The following is a description of a gene set: The gene expression program underlying the specification of human cell types is of fundamental interest. The study authors generated human cell atlases of gene expression and chromatin accessibility in fetal tissues. For gene expression, the study authors applied three-level combinatorial indexing to >110 samples representing 15 organs, ultimately profiling ~4 million single cells. The study authors leveraged the literature and other atlases to identify and annotate hundreds of cell types and subtypes, both within and across tissues. Our analyses focused on organ-specific specializations of broadly distributed cell types (such as blood, endothelial, and epithelial), sites of fetal erythropoiesis (which notably included the adrenal gland), and integration with mouse developmental atlases (such as conserved specification of blood cells). These data represent a rich resource for the exploration of in vivo human gene expression in diverse tissues and cell types. Human Gene Set: DESCARTES_FETAL_CEREBRUM_ASTROCYTES studied in species Homo sapiens from publication Cao J, O'Day DR, Pliner HA, Kingsley PD, Deng M, Daza RM, Zager MA, Aldinger KA, Blecher-Gonen R, Zhang F, Spielmann M, Palis J, Doherty D, Steemers FJ, Glass IA, Trapnell C, Shendure J (PMID 33184181) Marker genes curated from the annotated cluster as represented in the Descartes Human Gene Expression During Development database., and this is the list of marker genes: ADAMTS12, NCKAP5-IT1, NEK5, PPP1R9A-AS1, PDLIM3, CFAP46, ZBBX, LINC01354, PI15, SPATA17, WARS2-IT1, HS3ST3A1, CFAP99, FAM216B, LINC00844, C1QL4, ZNF474, LRRC9, AGT, SIRPB3P, SRGNP1 (NCBI Gene Id 106480246), SLC4A4, RSPH4A, SLC47A2, DNAAF3, PLA2G5, ODAD1, GREB1L, EFEMP1, CDHR4 (NCBI Gene Id 389118), ENSG00000188897, LINC03109, CFAP276, DNAH12, UBXN10, TMEM190, HKDC1, AQP4, MSTN, IRX5, PIK3C2G, CARM1P1, DRC1, GMNC, BTBD17, SPATA13, COL2A1, CKAP2LP1, CFAP157, IL33, FRMPD2, TOGARAM2, DTHD1, LINC01014, CFAP210, CLXN, WDR38, HSD17B6, COL27A1, CLDN10, LRRC74B (NCBI Gene Id 400891), FEZF1-AS1, CFAP43, THBS3-AS1, TEKT4, ADGB, GJB6, COL22A1, CFAP299, LINC00880, DNAI3, LRRC46, RPE65, TSHR, DRC7, ENTPD2, HOATZ, RNY1P5, VCAM1, ENSG00000247193 (NCBI Gene Id 442774), FGFR3, OBI1-AS1, SLC25A48, IRX3, CIMIP2C, CFAP126, DDO, CCDC198, KCNE5, LINC01088, CYP26B1, NEK2-DT, IDH2-DT, FYB2 (FYN binding protein 2), OTOG, CATIP, TEKT1, C7orf78, FAM181A-AS1, FOXJ1, AK7, FAM81B, GJB2, CPXM2, FOXB1, CD38, PIRT, VWA3B, FREM1, CYP26C1, GFAP, FAM181A, CFAP47, VIPR2 (vasoactive intestinal peptide receptor 2), SNX31, SHISA3, RMDN2-AS1, PLIN5, CFAP54, EFHD2-AS1, NOG, RFX2, LINC00698, CROCC2, PCAT4 (NCBI Gene Id 118425), CFAP52, CFAP107, IL5RA, FANK1, TNC, ANKRD66 (ankyrin repeat domain 66), SERPINI2, GLIS3, EGFR, DNAAF1, WFIKKN2, TECTB (tectorin beta), CIMAP3, TTC6, RPL7AP16, DNAH9, EFCAB12, USP2-AS1, RSPH1, LGR6, PRR18, KIF19, KIAA2012, MKX, DNAI2, DAW1, HHIP (hedgehog interacting protein), CDK6-AS1, PAX3, MORN5 (MORN repeat containing 5), LINC02253, LRRC10B, ACSBG1, SLC13A5, MAP3K19, DNAJB13, TPPP3, WDR49, SLC39A12, CAPSL, ETNPPL, FAP, FST (NCBI Gene Id 10468), ZMYND10, RNF43, LINC00689, ESPN, LINC00446, PIH1D2, VWA3A, BBOX1, DNAI7, E2F3P2, ARHGEF26, CFAP77, C1orf87, DNAH7, HOGA1, CRNDE, ENSG00000262999, ENSG00000259636, CFAP73, SPAG6, SNRPF-DT, MSX2, FLNC, CFAP57, ALDH1L1-AS2, USH1C, RPL31P54, PI16, TNFRSF11B, PPP1R42, TTPA, C10orf105, LINC02552, WDR93, CFAP44, LRIG1, GDPD2